Given this list of marker genes SHISA7, UBE2D1, SLC25A30, UBE2L3, HAS2, TRMT61B (NCBI Gene Id 55006), ANXA4, ADGRV1, ASXL1, KIAA0232, PAQR3, EXOC6B, SLC38A1 (solute carrier family 38 member 1), E2F7, ELL2, PAK5, UBE2D3, GRTP1, SESN3, ARB2A, UBTD2, GUCY1A1, FLOT1, GABRA2, FAM161A, GGA3, TRIM33, WIPF1, RAB14, RIOX1, MTNAP1, TMEM265, LGALSL, KDM2B, CCDC82, TBP, HNMT, MTSS2, ITPK1, LIPT2, AHSA2P, TMOD3, MSL3, SOSTDC1, NKAIN2, C2orf69, KRT39, GPR158, CTTNBP2NL, PRKAB2, UBR5, CLOCK, KANSL1L, DCX, BIRC6 (NCBI Gene Id 57448), GHITM, MOSPD1, SNAP91, RAPH1, WDR37, SLC26A9 (NCBI Gene Id 65013), ROBO1, TMEM185B, FGR, LPAR3, KRAS, WDR20, MXD3, PIMREG, SCN1A, NRG3, TJP1, DNM3, MAP3K2, CSMD3 (NCBI Gene Id 317683), STAU1, NUP43, CIMIP6, CNOT6, TM4SF1, DCLRE1C, MFAP1, LEF1, TNPO1, here is a description of the gene set: from publication Chen Y, Wang X (PMID 31504780) species: Homo sapiens Human Gene Set: MIR4519 Genes predicted to be targets of miRBase v22 microRNA hsa-miR-4519 in miRDB v6.0 with MirTarget v4 prediction scores > 80 (high confidence targets).